The following is a description of a gene set: Human Gene Set: GOBP_POSITIVE_REGULATION_OF_CELL_ACTIVATION species: Homo sapiens Any process that activates or increases the frequency, rate or extent of activation., and this is the list of marker genes: NSD2, TYK2, CD70, IL6, SOX13, HLX, EPO, LGALS8, BCL2, TRAF6, MIR30B, GATA3, MPL, VAV3, HLA-DRB3, CRLF2, PTPRC, IL12RB1, MDK, TACR1, VTCN1 (NCBI Gene Id 79679), MIR145, TIRAP (NCBI Gene Id 115469), EFNB1, RIPK2, CD276, EPHB2, HLA-DOA, ANXA1, SMARCD1, TNFSF9, PPP2R3C, DPP4, BMI1, NCKAP1L, TREM2 (triggering receptor expressed on myeloid cells 2), TNFSF11, CLEC4D, TLR6, SHH, IL15RA, BRD2, KLRC4-KLRK1, LEP, CD226, LGALS9, SRC (SRC proto-oncogene, non-receptor tyrosine kinase), TNF (tumor necrosis factor), SASH3, SOX12, ZBTB1, PRKAA1, FOXO3, PHF10, EBI3, EGR3, NOD2, TNFRSF14, PBRM1, MYB, GPR65, CD209, MAP3K8, LYN, ICOSLG, TGFB1, HAVCR2, TBX21, WNT3A, NCK2, CD28, HLA-DPA1, SIRPA, LILRA2, GPAM, CD27, IL18, PIK3CD, ZP3, MLH1, KARS1, XBP1, RAG1, SHLD2, CD86, SOX4, IL15, GP1BB, SLC39A10, DHPS, RHOA, STAP1, CD46, CD80, DDR2, RPS3, TGFBR2, CD24, RUNX1, ACTL6A, SPACA3, APP, PCK1, CCL2, TCF3, KLRK1, CD40LG, RASAL3, RPL13A, IHH, CARD11, CCL21, STAT5B, THBS1, SIRPG, ABL1, PLEK, LCK, FLT3LG, VAV1, HES1, HMGB1, CDKN1A, BRD4, LILRB2, CCL3, MIF, MIR92A1, MMP8, DUSP10, IL1A, PCID2, SPI1, IGF2, BRD7, PRKDC, VCAM1, TLR9, SELENOK, BTN2A2, LILRB4, HLA-DPB1, IL10, HLA-DQA2, CD4, HAVCR1, IL23R, ADAM8, HLA-DQA1, NECTIN2, FCGR3A, ACTL6B, CSK, FCRL3, TNFRSF4, FLNA, SART1, CD160, TLR4, LILRA5, PYCARD, CD3E, IL36B, VSIR, CD55, TNIP2, HLA-DQB2, SELP, BLOC1S6, ZBTB16, EXOSC3, ZAP70, CBFB, IL12A, BTK, PNP (NCBI Gene Id 4860), THY1, IL7, TYROBP, NLRP3, CD2, CCL5, CTSC, TICAM1, IL4I1, MYD88, LILRB1, KLHL25 (kelch like family member 25), MSH2, ACTA2, AP3D1, STAT5A, HMCES, SMARCC2, CD1D, CCL19, KMT5B, SMARCC1, TMIGD2, ARID1B, IL33, ITPKB, CD200, ATAD5, TNFSF13B, CHRNB2, YES1, SIRPB1, CYRIB, FOXP3 (forkhead box P3), SHLD1, AMBRA1, EFNB2, NFKBID, PRKCZ, KITLG, SMARCA4, EXOSC6, PAXIP1, TSLP, TNFSF14, VNN1, TFRC, WNT10B, PTPN6 (protein tyrosine phosphatase non-receptor type 6), AKT1, CR1, EP300, PPP3CA, HLA-G, MIR21, SPN (NCBI Gene Id 6693), AXL, MIR130A, TESPA1, DOCK8, AIF1, KMT5C, PRLR, FBXO38, TNFRSF13C, GLI3, IL16 (interleukin 16), IL23A, HLA-DRB5, RUNX3, CD40, B2M, HLA-DQB1, INPP5D, CD320, TAFA3, KAT5, DDRGK1, IL6ST, NKAP, IFNG (interferon gamma), ADA, TP53BP1, BST1, CYLD, NR5A2, CAPN3, GP1BA, CD83, IL1B, FGF10, KLHL22, JAK2, CAV1, CCR7, PEAR1, IRS2, IL21, YWHAG (NCBI Gene Id 96443), IL12B, HLA-DMB, SMARCD2 (SWI/SNF related, matrix associated, actin dependent regulator of chromatin, subfamily d, member 2), MAD2L2, FYN, PTPRJ, BCL6 (NCBI Gene Id 604), RPS6KA1, ARID1A, GP9 (NCBI Gene Id 2815), IL1RL1, MIR142, HSPD1, SPTA1, FADD, MALT1, CCR2, CEBPA, OPA1, ZP4, ZMIZ1, IL4R, BAD, NR4A3, SHLD3, ABL2, SPHK2, CLCF1, TNFSF4, MTOR, GLI2, CLEC7A, PRKCQ, FLOT2, SOX15, MIR128-1, MEF2C, SMARCA2, PDCD1LG2, IGF1, PTPN11, SMARCE1, LRRK2, RARA, CD274, CD74, TOX, SLC7A1, HLA-DRB4, XCL1, ZNF335, RHOH, GAS6, HSPH1, SMARCB1, LGALS1, SLAMF1, PIK3R6, HLA-E (major histocompatibility complex, class I, E), PMS2, PELI1, HLA-DRB1, TTBK1, BCL10, RASGRP1, IL2RA, LBP, EFNB3, IL2, CORO1A, ICOS (NCBI Gene Id 29851), HHLA2, NFATC2, CD38, SMARCD3, RIF1, NFKBIZ, HLA-A, CD5, SOCS1, IRGM, PDPK1, BLOC1S3, ZBTB7B, PLPP6, NCK1, WNT5A, SHB, CLECL1P, XRCC6, SVEP1, SYK, HLA-DOB, LEF1, CD47, JUND, DNAJA3, IL1RL2, IL4, AGER, CD81, PLA2G4A, IL2RG, IL13, HLA-DMA, IGFBP2, ACTB (NCBI Gene Id 60), CCDC88B, SH3KBP1, STAT6, HLA-DRA, GPR183, AP3B1, TAC1, IL7R (NCBI Gene Id 3575), GP5, BTNL2, ARID2 (NCBI Gene Id 57676), AKIRIN2, SOCS5, FCHO1, MMP14, TNFSF13, CD6, IL5